The following is a description of a gene set: Genes having at least one occurrence of the motif RAARTGAAACTG in the regions spanning 4 kb centered on their transcription starting sites. This matches the IRF8 transcription factor binding site V$ICSBP_Q6 (v7.4 TRANSFAC). Human Gene Set: ICSBP_Q6 studied in species Homo sapiens, and this is the list of marker genes: USP18, HOXB7, CCDC6, CREBZF, ELAVL2, USPL1, PLP1, GRIPAP1, ITPR3, DAGLA, CELF3, B2M, USP28, IL22RA1, SP8, CCDC148, GZMK, TNFSF13B, ATP11C, NFKB1, KRT12, NIPBL, ST3GAL4, TFEC, SREK1, TNFRSF19, DUSP10, MOV10 (NCBI Gene Id 57723), ATP10A, ARHGEF6, RIPK2, THBS1, PIK3R3, SATB2, LRP2, CASK, SIK3, ITPR1, ENTPD1, DLG2, LY75, SCML1, SOCS1, RAPGEF6, FUT8, NOL4L, SKIDA1, ATP5PD, TWIST1, ECM2, TBX1, ELK4, TMPRSS11A, KLHL13, CBX4, FAM53B, PSMA3, P2RY13, HAS3, ZBTB18, CPEB4, TSKU, MPDZ, CNTFR, RRBP1, SOS1, PRKD2, TFDP2, ZNF407, TEK, DAPP1, TNFSF15, PARP12, STAT6, RCOR1 (REST corepressor 1), POU4F1, CTSS, NPR3 (natriuretic peptide receptor 3), KDM2A, TAP1, SLC11A2, IRAG2, GPR22, ERBB2, FNBP1L, UBA7, COL4A2, MEIS2, IL27, SLC15A3, ASPA (NCBI Gene Id 443), PLD5, TCF15, CYP7A1, BCL11A, LAMA3, HOXA13, SP140, SP110, TGIF1, CACNA1C, IKZF2, KYNU, COL4A1, LINC01565, UBR3, ISG15, ESR1, RAD51AP1, FGF6, HPCAL1, CXCL16, FRY, IFIH1, H1-2, PSMB9, MAP3K11, CDK6, KCNJ1, PARP9, DTX3L, NT5C3A, R3HDM2, IL1RAPL1, BTAF1, WDPCP, PTK2, TOR1AIP1, USF1, LGALS8, ZPBP2, BBX, ZBTB33, TRPM3, EREG, LINC02363, ASCL2, MAP2K6, TLR7, ANGPTL4, ZER1, LGI1, ZNF296, NPAS3, MED13, CSAD, PURA, PAX3, ENPP2, VGLL4, CCDC140 (NCBI Gene Id 151278), XRN1, LY86, DGKA, FES, ZNF366, CYB5B, CXCR4, NDRG3, PPARGC1A, IRAK1, NKX2-2, CHD6, ADAR, SLITRK6 (NCBI Gene Id 84189), AIF1, HIVEP1, IFI35, HOXA3, GATA6, SEMA6D, IFIT3, BST2, SYNCRIP, ADAM8, TAPBPL, ZIC5, PIGR, CITED4, LURAP1L, IDO1, IFNL2, ARMCX6, IFI44, RBCK1, BANK1, FMR1 (fragile X messenger ribonucleoprotein 1), TAPBP, DIO2, WDR82, CMTR1, CRACR2B, FERRY3, MXI1, SYNE2, HNRNPD, ZMYND15, NABP2, TOP1, TCIRG1, IFNL3, HAPLN1, BATF2, NRG4, EPN1, EIF5A, PPP2R5C, RBM39, MAML3, IL21, GSDMD (NCBI Gene Id 79792), LYSMD2, MSX1, TNFRSF17, PRDM16, ZEB2, CYB561D1, MGAT4A, TSPAN2, PCDHGC3, EMP1, CDKN2C, DNAH6, OTX1, OSR2, IFNB1, SLC12A7, CABLES1, SORBS1, MCUB, KCNMB3, HDAC4, PSMB8, LRRN3, ALDH1A1, TRMT112, PYM1, PIGV, PRDX5, TUBB6, ARL5B, FGF9, ZBP1, DDB2, HMCN1, JADE2, CHST1, CASP7, PKP4, SIX1, IL18BP, ZFPM1, PHF6